The following is a description of a gene set: Mouse Gene Set: MP_INCREASED_INCIDENCE_OF_INDUCED_TUMORS species: Mus musculus from publication Motenko H, Neuhauser SB, O'Keefe M, Richardson JE (PMID 26092688) Mouse genes annotated to increased incidence of induced tumors (MP:0002021) retrieved from the Mouse Genome Informatics database via MouseMine, and this is the list of marker genes: Polg, Apc, Dmtf1, Zfp82, Cd226, Ercc2, Ptgs2, Ercc6, Bub1b, Pim1, Tcf3, Rhob, Atp6v0a2, Tnfsf10, Ifnar1, Lyst, Bub1, Nfe2, Cop1, Prf1, Blm, Adam28, Mad2l1, Ifnar2, Xpa, Wif1